Given this list of marker genes FLT3LG, UBC, CBL, RPS27A, UBB, UBA52, FLT3, here is a description of the gene set: studied in species Homo sapiens Missense and splicing mutants have been identified in the E3 ubiquitin ligase CBL in a number of cancers including acute and chronic myeloid leukemias, among others. These cancers show elevated signaling through FLT3 as a result of impaired CBL-mediated downregulation of the receptor. part of: FLT3 signaling in disease Reactome Pathway: FLT3 signaling by CBL mutants